The following is a description of a gene set: Genes up-regulated in comparison of IgD- peripheral blood B cells versus dark zone germinal center B cells. Human Gene Set: GSE12845_IGD_NEG_BLOOD_VS_DARKZONE_GC_TONSIL_BCELL_UP studied in species Homo sapiens B cells from human tonsil and blood were sorted using flow cytometry. The human samples were processed immediately ex-vivo using markers for known B cell subsets. from publication Longo NS, Lugar PL, Yavuz S, Zhang W, Krijger PH, Russ DE, Jima DD, Dave SS, Grammer AC, Lipsky PE (PMID 19023113), and this is the list of marker genes: MAGEA6, CD63, IGHM, GUSBP11, SUB1, FAM89B, NUDT4, ETHE1, TRIO, ITM2A, RAP1GAP2, RNF11, JRK, BHLHE41, IER2, TMEM109, SLC25A28, MAP3K5, KLF8, ALDOB, NKG7, HINT1, RPS6KB2, SLC7A7, SFXN3, FHL1, C11orf24, ITM2C, MANEA (NCBI Gene Id 79694), NAGPA, NTAN1, CENPB, SLC24A1, MAVS, RETSAT, SIL1, PCK2, WDR13, DOK2, NAALADL1, PLP2, C10orf95-AS1, PPIB, EIF2B3, IGLJ3, SPSB3, BTN3A1, CREB3L2, ITPK1, IQGAP2, IFNAR1, ITGB7, CTDP1, FSTL3, UNC93B1, RPN1, BCKDHA, TES, ITGA4, IGKV3-20, TIMP1, H2AC6, LDLR, SCAMP3, PPOX, BLVRA, RMDN3, TNFRSF1B, S100A11, NOD2, YIF1A, RNF126P1, RNH1, SMAGP, RETREG3, RNF31, BMS1P20, TBX21, GNG7, SERP1, THAP11, PCYT1A (NCBI Gene Id 5130), LITAF, NXPH4, UFC1, UCK2, USO1, ATXN7L1, PEX16, DIPK1A, NLRP1, ITGA3, DNASE2, HLA-A, LAMC1, VIM, HCK, GAA, HAX1, PPP1R11, TAGLN2, HSPA1L (heat shock protein family A (Hsp70) member 1 like), CFLAR, SEC61A1, RAPGEF1, CASP8, PLXNC1, LILRB4, IMPDH1, CTC1, KRT36, CRYL1, CERS6, NHEJ1, DRAM1, CLCC1, CTIF, TLE1, MYDGF, FNDC3A, CD151, IGKV1D-13 (immunoglobulin kappa variable 1D-13), ZNF706, HLA-E, TMT1A, TAPBP, PUS7, PBXIP1, DOC2B, MAGED2, CAPN3, DPM3, RASSF1, DECR1, TRAF3IP3, SELPLG, ADAM28, TOP6BL, EPRS1, HOXB1, HMOX1, BUD23, UBA7, RSAD1, TRAPPC3, RNPEPL1, ITCH, FASTK, CTSF, DYRK4, CDK16, ICAM4, RAP1GDS1, SSR4, CD86, JAK2, WFS1 (NCBI Gene Id 94141), CASP7, PF4, EPHB6, PSME2, DNAJC3, RPS6KA2, ABCA5, PDE8A, APH1B, IGKV1-5, DIDO1, CNPY2, MYL10, TLE5, IGLV4-60, MZB1, TMEM223, NPC2, BTD, ECHDC2, CLIC3, PDXK, IGKC, THAP7, PCDH9, RPN2, BAIAP3, FKBP11, RALGPS2, PECR, JHY, ABHD14A, PPBP, CRY1, GSE1, FGR, FTSJ1, ATP6AP2, ARID3A, TMEM184B